The following is a description of a gene set: Triglyceride biosynthesis Mouse Gene Set: REACTOME_TRIGLYCERIDE_BIOSYNTHESIS studied in species Mus musculus, and this is the list of marker genes: Lpin3, Gykl1, Gpam, Lpin2, Gk2, Gpat2, Mogat1, Dgat2, Agmo, Dgat1, Gk (glycerol kinase), Mogat2